Given this list of marker genes IBTK, BEX2, VARS1, PPT2, ANKFY1, CCDC88A, MYCBP2, NLGN2, DYNLT1, POU3F4, CPOX, CMTM7 (CKLF like MARVEL transmembrane domain containing 7), INPP5D, PHAF1, DEPTOR, DDX3Y, MLYCD, SARS1, KLF13, EIF2B4 (NCBI Gene Id 8890), HIBADH (NCBI Gene Id 221893), MT3, ACSS1 (acyl-CoA synthetase short chain family member 1), KLHL10, PRODH, ANXA9, PLA2G2D, CSTF3, PRMT2, PPP1R21, NME7, GRPR, BRD4, CCM2, GCSAM, CPSF4, NOCT, UBXN10, KMT2A, NCBP1, SMCO4, PDXDC1, FGF21, CCDC88C, CYB5RL, CUEDC1, HOXB13, PHLDA3, BLMH, TNRC6A, VAMP5, CLEC10A, UBXN4, LSP1, TBC1D17, SART1, SCRIB, MAP3K11, MT1E, HM13, TAOK1, HBEGF, SLC39A7, SNRNP70, LTB, CHAD, SYVN1, RMDN3, APC, CFD, MT2A, PTPRE, SYNE1, MAPK8IP3, ATG2A, NAGS, ACBD6, USP34, MUC5B, ATP1A3, CYP1B1, LAMA5, EIF6, PLVAP, ATP6V0A1, AXIN1, DSTYK, CLCF1, CP, ARPC1B, NXN, OTUD7B, MINDY1, PPIG, LIMD1 (NCBI Gene Id 8994), SHANK3, ZCCHC3, SPEN, C1QB, NFYC, ICA1, SNRPA, MRPS7, PTPN13, ZNF385A, ABCA7, YJEFN3, VWF, DGAT1, ACAA1, MAN2C1, PPY, AGR3, ADISSP, IGFBP6, VCAM1, ZNF112, ARFGAP1, TRIM2, SLC12A4, RPP25L, USP26, LIPE, MYL6B, CYSTM1, LDHB, SLC6A20, ATF7IP2, SEC16A, PABPN1, OPN1SW, BAMBI, SPTBN2, WNK4, EFNB1, RPS27, XPR1, C4B, MERTK, PKDCC, TNFRSF13C, BIK, BCL3, HOXB2, MAPK7, TNFAIP8, ARHGAP31, METRN, ACOT7, NSMCE1, ENDOG, FERMT3, PPP1R37, HP, GLCCI1, SPEF1, ANKRD33B, CELSR2, LCMT1, SPHK1, IGHM, ARF5, TSNAXIP1, OXTR, CELSR1, ZC3H11A, PIGR, NOP53, MIF4GD, MMP14, RLIM, IGLL1, KRTAP4-11, TNK1, EMSY, SFMBT2, HS6ST1, UFSP2, PLXDC1, C19orf48P, MARCHF6, MED16, FOXJ1, LRRC49, DMBT1, VIPAS39, LRRC23, PRKD2 (protein kinase D2), CSF1R, UTY, BBS2, MYH14, EXOSC8, WASHC1, USP7, B4GALNT1, PRKG2, NPR3, KRT8, here is a description of the gene set: We previously identified toll-like receptor 4 (Tlr4) as a candidate gene responsible for ozone (O3)-induced pulmonary hyperpermeability and inflammation. The objective of this study was to determine the mechanism through which TLR4 modulates O3-induced pulmonary responses and to utilize transcriptomics to determine TLR4 effector molecules. C3H/HeJ (HeJ; Tlr4 mutant) and C3H/HeOuJ (OuJ; Tlr4 normal), mice were exposed continuously to 0.3 ppm O3 or filtered air for 6, 24, 48 or 72 hr. Affymetrix Mouse430A_MOE gene arrays were used to analyze lung homogenates from HeJ and OuJ mice followed using a bioinformatic analysis. Inflammation was assessed by bronchoalveolar lavage and molecular analysis by ELISA, immunoblotting, and transcription factor activity. TLR4 signals through both the MYD88-dependent and independent pathways in OuJ mice, which involves MAP kinase activation, NF-kappaB, AP-1, and KC. Microarray analyses identifiedTLR4 responsive genes for strain and time in OuJ versus HeJ mice (p<0.05). One significantly upregulated cluster of genes in OuJ were the heat shock proteins (Hspa1b; Hsp70), Hsp90ab1). Furthermore, O3-induced expression of HSP70 protein was increased in OuJ compared to HeJ mice following 24-48 h O3. Moreover, BAL polymorphonuclear leukocytes (PMN) and total protein were significantly reduced in response to O3 in Hspa1a/Hspa1btm1Dix (Hsp70-/-) compared to Hsp70+/+ mice (p<0.05). TLR4 signaling (MYD88-dependent), ERK1/2, AP-1 activity, and KC protein content were also significantly reduced after O3 exposure in Hsp70-/- compared to Hsp70+/+ mice (p<0.05). These studies suggest that HSP70 is involved in the regulation of O3-induced lung inflammation through the TLR4 pathway and provide evidence that HSP70 is an endogenous in vivo TLR4 ligand. studied in species Homo sapiens Genes down-regulated in comparison of lung tissue from wild type mice versus that from TLR4 deficient animals. Human Gene Set: GSE20715_WT_VS_TLR4_KO_LUNG_DN from publication Bauer AK, Rondini EA, Hummel KA, Degraff LM, Walker C, Jedlicka AE, Kleeberger SR (PMID 21543283)